The following is a description of a gene set: Goals/objectives: to identify various gene expression in B cell subsets derived from human PBMC and cord blood species: Homo sapiens Genes down-regulated in naïve B lymphocytes versus those from cord blood. from publication Suryani S, Fulcher DA, Santner-Nanan B, Nanan R, Wong M, Shaw PJ, Gibson J, Williams A, Tangye SG (PMID 19965666) Human Gene Set: GSE17186_BLOOD_VS_CORD_BLOOD_NAIVE_BCELL_DN, and this is the list of marker genes: RPLP2, SPICE1, RCBTB2, ESYT1, METTL1, CBX4, PRF1, SLC6A19, FAM241A, CYTH3, NCKAP5L, PUS7, BAIAP3, AKAP12, SEPTIN9, TUT4, FAM8A1, DUSP28, SMG9, EFEMP2, SIAH1, SELENOW, KIAA1614, TSPO, SSBP2, SMPD5, IFIT1, CPN2, LRFN4, ZBTB2, MRM3, ARHGEF1, TPCN1, FBXL14, PDCD2, ZBTB11-AS1, DOCK2, C12orf57, MKRN2, BCAT1, TRMT1, JAK1, MS4A6A, ENDOG, IL2RG (NCBI Gene Id 3561), SLCO3A1, EZR, KCNMB4, ZSCAN25, TTC27, SMC4, GPATCH4, CHCHD10, ICAM2 (intercellular adhesion molecule 2), H2AJ, GPSM2, CDKN2D, SIDT2, STAT4 (NCBI Gene Id 6775), C16orf74, TPST2, PTGER2, IL2RB (NCBI Gene Id 3602), PPM1J, HMGXB3, ARL4D, FRMD8, TBC1D10C, FBXO4 (NCBI Gene Id 55087), OXCT1, KIAA0040, GARIN3, SAC3D1, RASAL3, CD5, LGALS3BP, TEX264, TNIK, HADHB, TMLHE, DGKZ, EIF1AD, ART4, PELI1, ZNF2, TMEM50A, PADI2, ADD1, HDAC7, RNF144A, SMKR1, GPR68, CCR9, TCF12, IL18RAP, NIPAL1, PSENEN, SLC25A53, PGK1, SLC2A9, SLC11A2, SETX, RALGPS2, GALK1, C19orf38, NLK, CMSS1, USP36, OXTR, CCDC71, FLNA (NCBI Gene Id 8272), GRAMD2B, WDR74 (WD repeat domain 74), UQCC5, TMEM80, RNF167, MAT2B, IZUMO1R, GDPGP1, USP24, THNSL2, PLA2G12A, PIGP, NT5C3B, ANKRD9, RFTN1, ERF, TUBA4A, FASTK, TLE4, B3GNT5, DNAJC15 (NCBI Gene Id 29103), ADAMTS6, DAD1, MLLT6 (NCBI Gene Id 4302), MAN1A2, ANGPTL4, OSBPL5, RPL22L1 (ribosomal protein L22 like 1), RGS10, MIF, RABAC1, LTB, BACE1, UBE3D, GBP2, RPS18, RPLP1, NDRG2, CAPRIN2, HADH, SELENOP, ERCC1, RHOH, RIMOC1, CARD6, GARRE1, LGALS9B, TTLL12 (tubulin tyrosine ligase like 12), ESYT2, SMPDL3A, ZNF654, SIGIRR, NPM1, ZDHHC20, MRPL58, ZHX3, GALNT7, ARL2BP, TMEM9, CEP97, RP9, SPATA13, HACD3, GALNT10 (NCBI Gene Id 79615), ATP2A3, ZNF281, SRSF12, TBL2, KIF1B, PRKCH, DDX11, ZDHHC15, IQGAP2, MDGA2, PDHA1, C8orf58, PPP1R14B, BTBD6, SELPLG, CARNS1, UTP20, METTL27, DYRK2, WASHC3, MTHFD1L, ZNF260, G0S2, MPHOSPH9, RFFL